The following is a description of a gene set: Human Gene Set: GOMF_INTERLEUKIN_1_BINDING Binding to interleukin-1. studied in species Homo sapiens, and this is the list of marker genes: IL1RAPL1, PXDN, IL1RN, A2M, NLRP7, TRIM16, HAX1, IL36RN, IL1R1, IL1R2